Given this list of marker genes SLC4A1, SPTA1, EPB42, GPI, SLC2A1, SPTB, ANK1, here is a description of the gene set: Spontaneous hemolytic crises Human Gene Set: HP_SPONTANEOUS_HEMOLYTIC_CRISES studied in species Homo sapiens